Given this list of marker genes CREBBP, H2BC21, H2BC9, CEBPA, PDK4, MED4, MED20, MED12, MED27, WDR5, MGLL, H2BC11, H2AC6, CCNC, MED23, ACSL1, GPS2, H2AC4, MED1, H2BC13, MED16, MED17, ASH2L, PEX11A, H3C15, NCOA6, PHLDA1, H2AJ, DPY30, PPARG, MED7, ELOVL5, CDK8, LPL, H2BC15, MED6, HDAC3, NCOA2, PPARGC1B, LPIN1, PLIN2, PLIN1, MED13, H2BC1, NCOR2, DGAT2, H2AB1, ABL1, LIPE, THRSP, PAGR1, CIDEC, H3-3A, KMT2C, H2BC5, H2AC18, KMT2D, SCD5, H2AX, NCOA1, NR5A2, MED30, H4C1, SIRT1, CDK5, RB1, GPAM, H2AZ2, H2BC17, MED31, PAXIP1, ANGPTL4, FABP4, EP300, CD36, H2BC12L, AGPAT2, H2AC7, H2BC26, SCD, H2AC20, MED14, H3C1, RXRA, H2AC14, ADIPOQ, NCOA3, PPARGC1A, PLIN4, MED24, TBL1X, RBBP5, TBL1XR1, H2BC3, PNPLA2, MED10, NCOR1, AJUBA, H2BC4, H2BC14 (H2B clustered histone 14), H2BC12, ACSS3, KDM6A, here is a description of the gene set: part of: Epigenetic regulation of gene expression by MLL3 and MLL4 complexes Reactome Pathway: Epigenetic regulation of adipogenesis genes by MLL3 and MLL4 complexes species: Homo sapiens During adipogenesis, the KMT2D (MLL4) complex preferentially localizes to active enhancers, marked by the presence of mono- or dimethylated histone H3 lysine-4 (H3K4me1/2, residue K4 corresponds to residue K5 in nascent histone H3), acetylated H3 lysine-27 (H3K27ac), and the presence of RNA Pol II. KMT2D localizes to these active enhancers together with the adipogenic transcription factors CEBPB, CEBPA, and PPARG, and is especially enriched at active enhancers that are co-occupied by CEBP and PPARG. Single Kmt2c (Mll3) knockout in mouse brown preadipocytes led to a modest decrease of H3K4me1, while double Kmt2c;Kmt2d (Mll4) knockout led to a global decrease of H3K4me1/2. Most MLL4-binding sites are marked by both H3K4me1 and H3K4me2 during adipogenesis. Double knockout of Kmt2c and Kmt2d in differentiating mouse adipocytes prevented increase in H3K4me1/2, H3K27ac, Mediator complex and RNA Pol II on adipogenic enhancers, specifically on Cebpa-positive and Pparg-positive gene loci. KMT2D-dependent deposition of H3K4me1/2 marks was also detected on some adipogenic promoters, but was less pronounced than on adipogenic enhancers. Deletion of Kmt2d significantly decreased expression of genes associated with Kmt2d-positive adipogenic enhancers. The expression of KMT2C, the catalytic subunit of the MLL3 complex, is upregulated during brown adipocyte differentiation.<br><br>Transgenic mice that express catalytically inactive form of Kmt2c (Lee, Saha et al. 2008; Lee, Lee et al. 2008) or that have a heterozygous loss of Kmt2d are resistant to fatty liver formation induced by high-fat diet. Expression of a large portion of high-fat diet induced genes in mouse liver requires Kmt2d. Among the defined transcription factors that promote high-fat diet-induced hepatic steatosis (ChREBP, SREBP1c, LXRs, and PPARG), ChREBP and SREBP1c do not interact with KMT2C/D.<br><br>Gomisin N, a lignan isolated from magnolia-vine (Schisandra chinensis) was shown to inhibit, without cytotoxic effects, differentiation of mouse 3T3-L1 preadipocytes by inhibiting mitotic clonal expansion during early adipogenesis. Gomisin N treatment reduces KMT2D but not KMT2C mRNA levels, and also reduces the mRNA level of adipogenic transcription factors CEBPB, CEBPA, and PPARG, as well as their targets FABP4 (aP2) and FASN (FAS), inhibiting lipid accumulation and formation of lipid droplets in 3T3-L1 preadipocytes. In vivo, Gomisin N treatment in high-fat diet–fed mice reduced body weight and epididymal adipose tissue mass, and inhibited adipocyte enlargement. Moreover, in adipose tissue of high-fat diet–fed mice, Gomisin N alleviated hepatic steatosis and improved overall metabolic parameters.<br><br>The epigenomic reader BRD4, essential for both white and brown adipose tissue development but dispensable for adipose tissue maintenance, is enriched on active enhancers during the initial stages of adipogenesis and on promoters that associate with enhancers at terminal stages of adipogenesis. More than 90% of Brd4 genomic binding sites lose Brd4 in mouse preadipocytes that are double knockout for Kmt2c and Kmt2d. The majority of Brd4-bound enhancers are co-occupied by Kmt2d, Ep300 (p300), Cebpa or Cebpb, and Pparg. Brd4 knockout does not affect binding of Cebpb and Kmt2d to adipogenesis target genes nor does it affect deposition of activating epigenetic marks, H3K4me1 and H3K27ac, at these genes, but it reduces binding of transcriptional machinery (e.g. Med1, Tbp, RNA Pol II, Cdk9) and eRNA (enhancer RNA) production. Brd2 and Brd3 may be able to partially compensate for the loss of Brd4. Inhibition of Brd proteins by synthetic inhibitor JQ1 inhibits expression of Pparg targets Cepba, Fabp4 and Adipoq induced by rosiglitazone, a synthetic Pparg agonist. Brd4 was shown to physically associate with Cebpb. Conditional knockout mice in which Brd4 gene is deleted in progenitor cells of brown adipose tissue and muscle lineages die immediately after birth because of breathing impairment, exhibiting severe reduction in muscle mass and brown adipose tissue.<br><br>Based on mouse studies, at the onset of white and brown adipogenesis the accessory subunit of MLL3 and MLL4 complexes, PAGR1 (also known as PA1) is needed for induction of CEBPB and CEBPD transcription factors. Based on a study in immortalized mouse brown adipocytes, PAGR1 is recruited to the CEBPB gene promoter by activated CREB1, which is phosphorylated at serine residue S133 (p-S133-CREB1). Based on a study in mouse white preadipocyte cell line 3T3-L1, PAGR1 is recruited to CEBPD gene promoter by ligand-activated glucocorticoid receptor (GR).<br><br>Based on a study conducted using the mouse 3T3-L1 white preadipocyte cell line as a model system, dehydroleucodine, a sesquiterpene lactone isolated from Artemisia douglasiana (California mugwort) halts mitotic clonal expansion at the initiation of white adipogenesis. Dehydroleucodine decreases the phosphorylation of ERKs and AKT, as well as levels of CCNA, CCND, CDK2, and CDK4, while increasing the level of p27 (CDKN1B), resulting in G0/G1 cell cycle arrest of mouse white preadipocytes. Dehydroleucodine also downregulates JMJD2B and KMT2D, leading to downregulation of CEBPB and PPARG, respectively.<br><br>Expression of the histone 3 mutant H3.3 K4M in mouse brown preadipocytes impairs adipose tissue development, but when H3.3 K4M is expressed in already differentiated mouse brown adipocytes, the maintenance and thermogenic function of brown adipose tissue are not affected.